Given this list of marker genes OR7E87P, PPP1R14A, ZBTB38, RAC2, NICOL1, TESC, TMEM163, G3BP2, CSRP1 (cysteine and glycine rich protein 1), JADE2, IDI1, TMEM170A, RUSC1, ARSA, IFI30, CYTOR, SACS, SAMHD1, GLRX, MCHR2-AS1, GMNN, GDI2, FCHSD2, PKIG (NCBI Gene Id 11142), PLPP3, RETSAT, FAM217B (NCBI Gene Id 63939), PHB1, CD86, QDPR, MCOLN2, BEX5, MSRA, KLF6, FCRLA, CREG1, ACYP1, ZNF292, ANKRD33B, ANKMY2 (ankyrin repeat and MYND domain containing 2), CD24 (CD24 molecule), FAM168A, SRD5A1, FLOT1, FXN (NCBI Gene Id 2395), TNNC2, SYCE1, HES6, APBB1IP, ARID3A, PHTF2, ZMIZ1 (NCBI Gene Id 57178), NPEPL1, PAPSS1, MBD2 (methyl-CpG binding domain protein 2), STAMBPL1, SEMA7A, SNTB1, CHEK1, HIBCH, C10orf143, SNX10 (NCBI Gene Id 29887), ATPAF1, CABCOCO1, DOK7 (NCBI Gene Id 619409), NAB2, KLK5, TIGAR, B3GALNT2, TSPOAP1, POLR2E, PNISR (NCBI Gene Id 84956), PBK, GRIN2D, NIPA1, NUDT19, ID3, GPATCH2, TLR10, KPNA2, MGMT, ODF2, ZDHHC18, MGAT4A, KMT2A, DVL1, MAP4K4, RAB10, FAS, SKAP2, NUSAP1, SPAG7, APOBEC1 (NCBI Gene Id 339), JKAMP, ST14, SLC35D2, TRIT1, GCLC, LRRK1, BID, MDFIC, COMMD7, MT1F, GLIS1, NAV1, SLC6A6, STK38, DDC-AS1, CTSC, SPATS1, HELLS, RNASEH2C, RASSF2, NOL4L, SKP2, FERMT3, AQP7, PER3, LY96, AHR, GLS, DENND1B, LRP8, FMR1NB, EVA1C, GNAI2, OR7E19P, MLEC, SNED1, UHMK1, TIAM2, POP7, SOS1, TIFA (NCBI Gene Id 92610), SWAP70, IFITM2, UGCG, MCF2L2, ZMAT3, CKAP2, AIP, TIGD3, PDCD4, SPATS2, SLC16A14, TNFAIP8L1, TRIM25, RAD17 (NCBI Gene Id 5884), N4BP3, BLNK, CYP4F3, NT5DC1, EFCAB12, RTKN, PLBD1, SAMSN1, UHRF1, COX10, CD82, CAP2, C8orf34-AS1, GALNT1, ST3GAL5, LASP1, FAAH, VAMP1, CDC42EP3, OR5V1, RBMX2, ITIH2, CXCL14, VLDLR, XPR1, HAUS8, TLR7, CCNE1, STARD7-AS1, ACP5, EFL1, RPS3, USP48, RAB2A, INCENP, BTNL9, NOTCH3, ZNF589, THAP11, PPP1CC, CDNF, GNPDA1, CHMP2B, FKBP11, MGLL, CD2BP2, COTL1, SOWAHA, CWF19L1, LOXL1-AS1, here is a description of the gene set: studied in species Homo sapiens Human Gene Set: GSE21927_C26GM_VS_4T1_TUMOR_MONOCYTE_BALBC_UP Genes up-regulated in CD11b+ cells from BALB/c mice bearing: C26GM colon carcinoma versus 4T1 mammary carcinoma. Tumor growth is associated with a profound alteration of myelopoiesis, leading to recruitment of immunosuppressive cells known as myeloid-derived suppressor cells (MDSCs). Analyzing the cytokines affecting myelo-monocytic differentiation produced by various experimental tumors, we found that GM-CSF, G-CSF, and IL-6 allowed a rapid generation of MDSCs from precursors present in mouse and human bone marrow (BM). BM-MDSCs induced by GM-CSF+IL-6 possessed the highest tolerogenic activity, as revealed by the ability to impair the priming of IFN- -producing CD8+ T cells upon in vivo adoptive transfer. Moreover, adoptive transfer of syngeneic, GM-CSF+IL-6-conditioned MDSCs to diabetic mice transplanted with allogeneic pancreatic islets resulted in long term acceptance of the allograft and correction of the diabetic status. Cytokines inducing MDSCs acted on a common molecular pathway. Immunoregulatory activity of both tumor-induced and BM-derived MDSCs was entirely dependent on C/EBP transcription factor, a key component of the emergency myelopoiesis triggered by stress and inflammation. Adoptive transfer of tumor antigen-specific CD8+ T lymphocytes resulted in therapy of established tumors only in mice lacking C/EBP in myeloid compartment. These data unveil another link between inflammation and cancer and identify a novel molecular target to control tumor-induced immune suppression. We used gene expression analysis to identify those factors, secreted by tumor-infiltrating MDSC, which could drive emathopoiesis. Moreover we compare gene expression profile of tumor-induced MDSC, obtained from either the spleen and the tumor infiltrate of tumor bearing mice, and in vitro bone marrow-derived MDSC. from publication Marigo I, Bosio E, Solito S, Mesa C, Fernandez A, Dolcetti L, Ugel S, Sonda N, Bicciato S, Falisi E, Calabrese F, Basso G, Zanovello P, Cozzi E, Mandruzzato S, Bronte V (PMID 20605485)